Given this list of marker genes AP2S1, AP2A2, CLTA, LIPA, LDLR, NR1H2, APOC4, LDLRAP1, CES3, CUBN, SOAT1, HDLBP, AP2B1, UBB, NPC2, MYLIP, AP2A1, NPC1, NCEH1, LIPC, UBC, APOE, APOB, VLDLR, SOAT2, APOA1, LSR, NR1H3, SCARB1, UBA52, AP2M1, APOBR, AMN, APOC1, CLTC, RPS27A, PCSK9, here is a description of the gene set: species: Homo sapiens part of: Plasma lipoprotein assembly, remodeling, and clearance Circulating chylomicrons acquire molecules of apolipoproteins C and E and through interaction with endothelial lipases lose a large fraction of their triacylglycerol. These changes convert them to chylomicron remnants which bind to LDL receptors, primarily on the surfaces of liver cells, clearing them from the circulation.<br>Most very-low-density lipoproteins (VLDL) are converted to low-density lipoproteins (LDL) (VLDL remodeling pathway). A small fraction are taken up by VLDL receptors on extrahepatic cells, as annotated here. Clearance of LDL from the blood involves binding to LDL receptors associated with coated pits at the cell surface, forming complexes that are internalized and passed via clathrin-coated vesicles to endosomes, where they dissociate. The LDL particles move into lysosomes and are degraded while the LDL receptors are returned to the cell surface. This process occurs in most cell types but is especially prominent in hepatocytes. It plays a major role in returning cholesterol from peripheral tissues to the liver.<br>Clearance of circulating HDL particles involves particle binding to cell-surface SR-BI receptors, particle disassembly with rlease of pre-beta HDL (Silver & Tall 2001), and uptake of the latter mediated by cell-surface CUBN:AMN complex.<br>VLDLR internalization plays a clinically significant role in determining the efficiency of lipoprotein clearance from the blood. Reactome Pathway: Plasma lipoprotein clearance